The following is a description of a gene set: studied in species Mus musculus Mouse Gene Set: GOMF_STRUCTURAL_CONSTITUENT_OF_RIBOSOME The action of a molecule that contributes to the structural integrity of the ribosome., and this is the list of marker genes: Rpl19 (NCBI Gene Id 19921), Rpl36-ps12, Mrpl39, Rsl24d1, Rpl41, Rpl22l1, Mrps22, Rpl7l1, Rpl10, Rps16, Mrpl10, Uba52, Gm6133 (predicted gene 6133), Rps5, Mrpl47, Mrpl49, Mrpl33, Mrpl43, Rpl23, Rpl5, Mrpl30, Uba52-ps, Rpl39, Rps12 (ribosomal protein S12), Mrpl23, Mrps6, Mrps30, Rpl22, Mrps12, Dap3, Rpl3l, Rpl10-ps3, Mrps14, Rps4x, Rpl17, Mrps18a, Mrps35, Rps15a, Rpl7a, Mrpl57 (mitochondrial ribosomal protein L57), Rpl37rt, Rps13, Rps27rt, Rpl10l (ribosomal protein L10-like), Rpl36 (NCBI Gene Id 54217), Mrps11, Rps8, Rpl30, Mrps2, Mrps15, Rpl36al, Rpl35a, Mrpl14, Mrpl51, Ubb, Rps10, Rpl23a, Rpl7, Mrps34, Rpl34, Rpl9-ps6, Rpl6, Rpl32l, Rps26, Mrps31 (mitochondrial ribosomal protein S31), Rpl35rt, Rps11, Mrpl13, Rpl8, Mrpl21, Rpl38, Rps23, Uba52rt, Mrpl54, mt-Rnr2, Rps15, Fau, Rpl13a, Rpl27a, Rplp1rt, Rps21, Rps25, Mrpl41, Rps6-ps4, Mrps25, Rpl32, Rpsa, Mrpl9, Srbd1, Mrpl32, Rpl29, Mrpl55, Rpl31, Rpl18a, Rpl27rt, Mrpl16, mt-Rnr1, Mrpl18, Rpl10a (NCBI Gene Id 19896), Rps3, Mrps21, Rps18, Mrpl45, Rpl36a, Mrpl12, Mrps23, Rpl28, Mrpl17, Rpl34-ps2, Rps27a, Mrps18c, Mrpl34, Mrpl15 (NCBI Gene Id 27395), Mrpl19, Mrpl4, Rps27, Rpl34-ps1, Mrps10, Rpl12, Rpl14, Mrpl22, Rpl35, Mrps16, Rplp2, Mrps18b, Rpl13-ps6, Mrps9, Rplp1, Rpl4, Mrpl27, Rpl24, Rps9, Rps7, Rpl6l, Rps20, Rps24, Rpl21, Rps27l, Mrpl35, Rpl26 (ribosomal protein L26), Mrps5, Rpl39l, Mrpl28, Rps2, Mrpl11, Rps6, Rplp0, Mrpl36, Rpl37a, Rps17, Rps19, Rps29, Mrps17, Rpl11, Mrpl24, Rpl9-ps1, Rpl18, Mrps7, Rpl15, Rpl27, Rps3a1, Rpl3, Rps28, Rpl37, Rpl9, Mrpl1, Mrpl2, Rps14, Mrpl3, Rpl17-ps8, Mrpl37, Mrpl46, Mrpl20, Mrpl52, Rpl13, Mrps24